Given this list of marker genes Nrxn1, Cped1, Mindy2, Aebp2, Nufip2, Clk3, Elfn2, Sh3d19, Tpcn1, Mitf, Mink1, Kcnb1, Ptprn2, Marchf5, Ddhd1, Gm20939, Ark2c, Gdpd5, Mslnl, Jdp2, Htra3 (HtrA serine peptidase 3), Serinc5, Myo16, Zfp654, Csde1, Rnf103, Piezo2, Creb5, Fbxo41, Nhsl3, Gm14322, Pcnp, Dkk2, Gm6710, Spag8, Creb1, Skil, Serpini1, Zfp971, Poglut3, Shc4, Nucb2 (nucleobindin 2), Erc2, St18, Vwc2, Samd8, Map3k14, Nacc1 (nucleus accumbens associated 1, BEN and BTB (POZ) domain containing), Gm14325, Gpc5, Jade2, Gm14391, Ss18l1, Hivep1, Lmo7, Strn, Napepld, Gm14434 (NCBI Gene Id 668039), Stx11, Glce, Pitpnb, Arid4b (NCBI Gene Id 94246), Cd200r1, Tbl1xr1, Fam229a, Otud7b, Celf5, Ankrd44, Tac1, Plxdc2, Ndrg4, Rasal2, Derl2, Rabgap1l, Msl2 (MSL complex subunit 2), Ebf3, Mvb12b, Gm4724, Galnt3, Ttll7, Tpbgl, Tph1, Tmem154, Ddx3x (DEAD box helicase 3, X-linked), Mea1, Zfp931, Mysm1, Gpr171, Cask, Mier3, Atl3, Rorb, Hycc2, Sertad2, Ptpra, Phf24, Hlf, Epha8, Igf2 (insulin-like growth factor 2), Gm2026, Lhx9, Ipo8, Slco5a1, Rock1, Camkmt, B3gat1, Scai, Lypd6b, Igfbp7, Plgrkt, Mast4, Phf6 (NCBI Gene Id 72524), Thsd7a, Vat1, Col9a3, Tab3, Ubr3, Pld5, Brinp3, Tgfb1i1, Chm, Spred1, Ppp1r26, Rbl2 (RB transcriptional corepressor like 2), Ppp1r12c, Rnf41, Tmprss3, Tmem129, Prkg1, Tpm4, Magi2, Lgr4, Lin28b, Brcc3, Rfx3, Mospd1, Gpr161, Fanci, Inhbb, Ubn2, Pold3, Pkn2, Cttnbp2nl, Tm9sf5, Ppp4r3b, Atxn1, Gfpt1, Sass6, D430041D05Rik, Ermp1, Zfp518b, Cdc25b, Pip4k2a, Tiam2, Insyn2b, Eif5a2, St8sia4, Gja1, Dcbld2, Spsb1, Grip1, Fam13a, Tnc, Pex5l, Serp1 (stress-associated endoplasmic reticulum protein 1), Ddx41, Bpnt2, Pag1, Ripor2, Rassf5, Trio, Klf12, Setbp1, Snx18, Tmem25, Zfx, Abl2, Tmub2, Cert1, Anks1b, Ccer2, Hmox1, Tafa3, Numb, Rgs17, Cfap68, Septin2, Fat3, Socs6, Pheta1, Rabep1, Kif2b, Lcorl, Scn4b, Herpud2, Gucy1a2, Shisa6, Ncan, Pak5, Tacc1, Mdga2, Smchd1, Kif21b, Igsf11, Ret, Rhobtb1, Hs3st2, Mbnl1, Cpne8, Dlg2, Zbtb11, Dnaja2, Galntl6, Sh2d1a, Kirrel3, Plekhf2, Stam2, Kctd9, Wipf1, Eif2ak3, Galnt13, Nrxn3, Golm1, Gpr153, Ano4, Onecut2, Sde2, Camsap1, Slc1a2, D630045J12Rik, Slc35f1, AU021092, Fgf12, Tnfaip1, Hic2, Krt222, Rab3b, Zdhhc8, Hoxa1, Pla2g12b, Cdk6, Gnai2, L3mbtl3, Tubg1, Tmed8, Tub, Ttll9, Col19a1, Robo1, Csmd3, Gm14308 (predicted gene 14308), Sgcz, Prlr, Rgmb, Gramd4, Net1, Rnf19b, Hcfc1 (NCBI Gene Id 15161), Lasp1, Mdga1, Sec22c, Wwox, Sh3rf1, Unc13a, Pclo, Lhfpl6, Larp4b, Pdzd2, Epb41l1, Sprr2e, Nudt12, Pik3r6, Plppr4, Fam3c, Rictor, Vopp1, Dpp4, Map3k2, Pcdh7, Usp24, Gm14326, Snx4, Adipor2, Cenpi (NCBI Gene Id 245603), Pdgfra, Trhde, Ehf, Slc5a3, Mid2, Exo1, Cdk19 (cyclin dependent kinase 19), Slc39a1, Cd27, Cpb2, Bltp3b, Wnt2b, Chst8, Mob1b, Ism2, Fzd4, Gpr155, Epc1, Rassf2, Rbl1, Zcchc4, Slc22a3, Nr1d2, Olfm3, Sfmbt2, Gm14296, Nup50, Purb, Mrps36, Zfp202, Rock2, Tmpo, Nav1, Slc4a7, Exd2, Acsl1, Klf8, Cacna1g, Zfp800, Dcun1d1, Lmo3, Bmi1, Kdm5a, Myorg (myogenesis regulating glycosidase (putative)), Phaf1, Plxnc1, Gca, Egr1, Syt13, Rab8b, Sema6a, Nr3c1, Adamts17, Rnf150, Arid4a, 2210418O10Rik, Jade1, Lrrc19, Celf4, Zfp975, Khdrbs1, Ablim3, Jakmip3, Ccdc6, Afap1l1, Ankrd17, Nmt2, Ccdc177, Slc12a2, Bmt2, Nectin1, Tet1, Cnot6l, Cdca7l, Zfp810, Hoxd8, Cbx5, Rb1cc1, Zfp804a, Hectd2, Kcnip3, Frmd4a, Satb2, Ppp1cb (protein phosphatase 1 catalytic subunit beta), Pax2, Rcbtb1, Cdc37, Neurl4, Sdc2, Ptprt, Zfp976, Iqck, Pou6f1, Specc1l, Klf9, Ube2h, Kcnk1, Hoxd10, Prkar2b, Brdt, Sgk3, Tmem132b, Rimbp2, 2510009E07Rik, Hectd4, Sycp2, Dync1i2, here is a description of the gene set: Mouse Gene Set: MIR_7026_3P species: Mus musculus from publication Chen Y, Wang X (PMID 31504780) Genes predicted to be targets of miRBase v22 microRNA mmu_miR_7026_3p in miRDB v6.0 with MirTarget v4 prediction scores > 80 (high confidence targets).